The following is a description of a gene set: part of: Downstream signaling of activated FGFR2 species: Mus musculus This event has been computationally inferred from an event that has been demonstrated in another species.<p>The inference is based on the homology mapping from PANTHER. Briefly, reactions for which all involved PhysicalEntities (in input, output and catalyst) have a mapped orthologue/paralogue (for complexes at least 75% of components must have a mapping) are inferred to the other species. electronically inferred by orthology from the curated human pathway Reactome Pathway: Phospholipase C-mediated cascade; FGFR2, and this is the list of marker genes: Fgf6, Fgf1, Fgf4, Fgf7, Fgf17, Fgf23, Fgf22, Fgf5, Fgf2, Fgf16, Fgf8, Fgf20, Fgf10